Given this list of marker genes TAGLN3, LIMD2, NHLH2, HAND1, THRB, CACNA2D2, PYCR2, SYNGR3, APOD, NRBP2, here is a description of the gene set: from publication Scherer CA, Magness CL, Steiger KV, Poitinger ND, Caputo CM, Miner DG, Winokur PL, Klinzman D, McKee J, Pilar C, Ward PA, Gillham MH, Haulman NJ, Stapleton JT, Iadonato SP (PMID 17651872) studied in species Homo sapiens Gene expression in human peripheral blood mononuclear cells was systematically evaluated following smallpox and yellow fever vaccination, and naturally occurring upper respiratory infection (URI). All three infections were characterized by the induction of many interferon stimulated genes, as well as enhanced expression of genes involved in proteolysis and antigen presentation. Vaccinia infection was also characterized by a distinct expression signature composed of up-regulation of monocyte response genes, with repression of genes expressed by B and T-cells. In contrast, the yellow fever host response was characterized by a suppression of ribosomal and translation factors, distinguishing this infection from vaccinia and URI. No significant URI-specific signature was observed, perhaps reflecting greater heterogeneity in the study population and etiological agents. Taken together, these data suggest that specific host gene expression signatures may be identified that distinguish one or a small number of virus agents. Genes up-regulated in peripheral blood mononuclear cell in adults (18-40) after exposure to YF-Vax, time point anyD Human Gene Set: SCHERER_PBMC_YF_VAX_AGE_18_40YO_ANYD_UP